The following is a description of a gene set: Mouse Gene Set: REACTOME_CREB1_PHOSPHORYLATION_THROUGH_NMDA_RECEPTOR_MEDIATED_ACTIVATION_OF_RAS_SIGNALING species: Mus musculus CREB1 phosphorylation through NMDA receptor-mediated activation of RAS signaling, and this is the list of marker genes: Rps6ka2, Creb1, Rps6ka1 (NCBI Gene Id 230803), Rps6ka3, Rps6ka6